The following is a description of a gene set: To gain insight into the function of DNA methylation at cis-regulatory regions and its impact on gene expression, we measured methylation, RNA polymerase occupancy and histone modifications at 16,000 promoters in primary human somatic and germline cells. We find CpG-poor promoters hypermethylated in somatic cells, which does not preclude their activity. This methylation is present in male gametes and results in evolutionary loss of CpG dinucleotides, as measured by divergence between humans and primates. In contrast, strong CpG island promoters are mostly unmethylated, even when inactive. Weak CpG island promoters are distinct, as they are preferential targets for de novo methylation in somatic cells. Notably, most germline-specific genes are methylated in somatic cells, suggesting additional functional selection. These results show that promoter sequence and gene function are major predictors of promoter methylation states. Moreover, we observe that inactive unmethylated CpG island promoters show elevated levels of dimethylation of Lys4 of histone H3, suggesting that this chromatin mark may protect DNA from methylation. from publication Weber M, Hellmann I, Stadler MB, Ramos L, Pääbo S, Rebhan M, Schübeler D (PMID 17334365) Human Gene Set: WEBER_METHYLATED_HCP_IN_FIBROBLAST_UP Methylated germline-specific genes with high-CpG-density promoters (HCP) in primary fibroblasts. species: Homo sapiens, and this is the list of marker genes: PHF7, DMRT1, SPAG6, SPATA4, PIAS2, SPA17